Given this list of marker genes TCP11X1, CYLC1, CIMIP4, ATP6V0A2, DCST1, SV2B, SPACDR, EPPIN, ARC, SSH2 (NCBI Gene Id 85464), RND2, TEKT3, TSSK1B, ADAM15, TMEM225, IZUMO1 (izumo sperm-oocyte fusion 1), TRIM36, ABHD2 (abhydrolase domain containing 2, acylglycerol lipase), TMPRSS12, CATSPER4 (cation channel sperm associated 4), SPACA3, TBXA2R, TBC1D21, PATE4, LRGUK, SPACA7, HEXB, CALCR, CSNK2A2, SYT8, TMEM95, CALR, ACTL9, CLK3, DYNLT4, SPACA4, ACTRT1, TSSK2, CFAP65, PLA1A, IL4I1, VDAC2, TRIP11, MROH2B, LYZL6, CAV1, SPINK2, SPAG17, CCDC62, TMEM190, SPESP1, SPAG9, POMT1, DLD, IQUB, PCSK4, FNDC3A, RAB6A, VPS13B, AKAP3, SKIL, ACRV1, PRKACA, SPACA9, EQTN (NCBI Gene Id 54586), CTNNA1, GNAT3, RACGAP1, KNL1, SLIRP, HYAL3 (hyaluronidase 3), TCP1, RAB3A, KIT, SPACA5, PRKG1, CAV2, CEP131, TEX22, STK31, SLC9A8, TCP11, FLOT2 (flotillin 2), ATP6V1E2, TEX101, TSSK4, CATSPER3, DCST2, TMEM210, LY6K, PPFIA3, CCDC136, RAB2B, VEZT, SNAPIN, SH3GL3, TXNDC8, CTSH, IQCF1, PLA2G10, FAM209B, MORN2, GOLGA1, ITGA1, CABS1, SEPTIN14, KIAA1210 (NCBI Gene Id 57481), SPAG6, CXADR, RCBTB2, NOTCH1, LYZL4, CT55, SERPINA5, PKDREJ, SPACA1, IZUMO3, SCNN1A, CRCP, BSG, ICA1L, MORN3, CD46, TCP11X2, ACTL7A, DKKL1, NCF2, SPATA1, SPACA5B, PRSS37, DRD2, TUBA8, CAPN11, SPACA6, FAM220A, LOXL1, MFGE8, SPATA16, PRSS55, ATP8B3, ZPBP2, OSBP2, ENKUR, RAB2A, DPEP3, SPAM1, ACRBP, ZPBP, ACR, USP8, CFAP119, GLIPR1L1, IFT20, FAM170B, IFT74, SPAG8, here is a description of the gene set: Human Gene Set: GOCC_ACROSOMAL_VESICLE studied in species Homo sapiens A structure in the head of a spermatozoon that contains acid hydrolases, and is concerned with the breakdown of the outer membrane of the ovum during fertilization. It lies just beneath the plasma membrane and is derived from the lysosome.